The following is a description of a gene set: Human Gene Set: GOBP_NEGATIVE_REGULATION_OF_MONOCYTE_CHEMOTAXIS Any process that decreases the frequency, rate, or extent of monocyte chemotaxis. studied in species Homo sapiens, and this is the list of marker genes: NBL1, SLIT2, GREM1, MICOS10-NBL1, DUSP1, SLAMF8, CCN3